Given this list of marker genes RAB11FIP4, APOBR, G2E3, IFNGR1, GNAS, KDM8, NIBAN1, MRPL27, LRRTM2, LY9, TMPO (thymopoietin), RALA (RAS like proto-oncogene A), CCNE2, CMA1, ITPK1, G0S2, LRP8, AUNIP, CENPS, APPBP2, GSR, MPND, LYAR, TRAF4, UBE2G2, MYL6, PCNT, TTK, CDR2, NSMCE2, UCHL5, CHAF1B, BTG3, EIF2AK3, POLE3 (DNA polymerase epsilon 3, accessory subunit), SDHD, ANXA7, SULT1A1, MTM1, ERCC6L, SPATA6, SAP30 (NCBI Gene Id 8819), ENO1, TBC1D31, PLXND1, BMP8A, CCNE1, AHDC1, SPPL3, BNIP2, GBP7, CD86, HSD11B1, LYPD3, ELOF1, ARAP2, LAMB3, PSMA1, BEND7, ST14, AGAP2, B4GALT5, PIAS1, RNF166, ISY1, H2BC5, KCTD20, MBD4, CCL4, USP46, XBP1, TMF1, EXO1, SNRPC, H2AX, CLTA, SH3GLB1, TICRR, HAUS8, PRR11, MED19, ALYREF (NCBI Gene Id 10189), TNFRSF1B, STMN2, FERRY3, TASL, TAF12, CCNF, BUB1, ANKRD11, SIRT1, SPAG5, PBDC1, RIOK3, IGSF11, CSNK2A1, SMS, RARS1, FAM131B, PSMD7, NFIC, OVOL2, MCM7, FHIP1B, RUNX3, KDM4A, PEPD, UGCG, SLC12A4, CAPN2, ZNF146, KNL1, S100A6, CENPJ, DOK2, TSPAN17, SMARCC2, CUZD1, CCND2, OTULIN, WDR62, UAP1, MEGF9, B3GAT3, RHAG, UCK2, SNHG3, KIF14, KPNA2, MLKL, DDIAS, KIF18B, SMC5, PA2G4, RECQL (RecQ like helicase), BRIP1, FGL2, CCT6A, LCMT1, KPNA3, TRAPPC1, JPH3, LSM2, ELOVL1, SLC52A3, EHMT2, RFC5, DIAPH3, MYEF2, HMGXB4, TFAP2C, THY1, JPT2, STIL, KMT5A, SPC24, PPP1R12A, NABP1, HMGB2, LFNG, VIM, STX12, TAFA3, STARD7, ARMC7, HDGF (heparin binding growth factor), GTSE1, ATP8B4, PASK, HNRNPAB (heterogeneous nuclear ribonucleoprotein A/B), NDUFB8, TUBE1, SLA2, CDK2, SCYL2, NMRAL1, GDAP2, ITGB3, CSE1L (NCBI Gene Id 1434), CSNK2B, MXD1, CRELD2, CDCA2, TENT5A, DCLK2, SEPHS2, ACAA2, FABP5, IDH2, SHISAL2B, GNPTG, FANCD2, ERN1, HIRA, KIF23, IPO5, PSPH, CA5B, METTL14 (NCBI Gene Id 57721), here is a description of the gene set: studied in species Homo sapiens Human Gene Set: GSE2128_C57BL6_VS_NOD_THYMOCYTE_UP Fetal thymic organ culture (FTOC) DC2.5 CD4+CD8+ thymocytes from B6g7 or NOD background. 0 or 16 hour after addition of the BDC mimitope Genes up-regulated in C57BL6 CD4 CD8 double positive thymocyte transgenic for the BDC2.5 TCR incubated with no peptide 0h versus NOD CD4 CD8 double positive thymocyte transgenic for the BDC2.5 TCR incubated with no peptide 0h. from publication Zucchelli S, Holler P, Yamagata T, Roy M, Benoist C, Mathis D (PMID 15780994)